The following is a description of a gene set: species: Homo sapiens The chemical reactions and pathways involving cortisol, the steroid hormone 11-beta-17,21-trihydroxypregn-4-ene-3,20-dione. Cortisol is synthesized from cholesterol in the adrenal gland and controls carbohydrate, fat and protein metabolism and has anti-inflammatory properties. Human Gene Set: GOBP_CORTISOL_METABOLIC_PROCESS, and this is the list of marker genes: HSD11B2 (hydroxysteroid 11-beta dehydrogenase 2), CYP11B2, BMP5, REST, DGKQ, CYP11A1, H6PD, CYP11B1, DKK3, CACNA1H, WNT4, BMP2